The following is a description of a gene set: Human Gene Set: GSE17721_CTRL_VS_PAM3CSK4_0.5H_BMDC_UP Genes up-regulated in comparison of control dendritic cells (DC) at 0 h versus those stimulated with Pam3Csk4 (TLR1/2 agonist) at 0.5 h. from publication Amit I, Garber M, Chevrier N, Leite AP, Donner Y, Eisenhaure T, Guttman M, Grenier JK, Li W, Zuk O, Schubert LA, Birditt B, Shay T, Goren A, Zhang X, Smith Z, Deering R, McDonald RC, Cabili M, Bernstein BE, Rinn JL, Meissner A, Root DE, Hacohen N, Regev A (PMID 19729616) mouse primary BMDCs were stimulated with tlr ligands and gene expression changes were profiled on Affymetrix arrays studied in species Homo sapiens, and this is the list of marker genes: SOX21, CDK2 (cyclin dependent kinase 2), UBA3, ABAT, DOCK2, NCOA4 (NCBI Gene Id 8031), HNRNPM, RANBP17, STARD3NL, RNF32, INO80C, SEPTIN8, SNRPD3, DLD, SCLY, NDUFAF1, STK16, TCF21, RNF5, RPL3L, PIK3AP1, CCDC137, IL9R, SERTAD3, SNAP23, KAT2B, KARS1, ITGA4, SOCS5, HSDL2, SH3GL2, PDE2A, PSME4, POLG, FBXW11, TMEM175 (transmembrane protein 175), INO80, UHMK1, SLC46A2, BNIP2, XPO4, SAE1, PPP4R2, EQTN, USP9X, VPS50, NAA40, CMTM6, AGL, CASP7, P2RY12, HNF1B, CCDC6, SENP2, UBE2N, JAK1, PFKL, C6orf120, ZNF14, ENTR1, EIF3K, PBX3, ECHDC1, ERLIN1, MGAT2 (NCBI Gene Id 4247), GCNT2, TP53INP2, CHMP7 (NCBI Gene Id 91782), CENPA, NDUFA7, CAMK2A, WDR43, PRPF38B, USP38, TAF4, CABP7, KYNU, VPS35, GATAD2A, SLC23A3, FKBP7, UMPS, USP15 (ubiquitin specific peptidase 15), COCH, TBPL1, LEPROT, MYO5B, ENTPD1, GCSH, UGT2B17, ANKRD28, FAR1, CELA1, TTC14, PLEKHA2, ASH2L, COL5A2, MTFR1, EVA1C, TMEM216, SHC1, NME6, CD44, IFT70B, ABL1, EPS15, LCN8, RIMOC1, HJURP, WRAP53, POLR3F, FAM117B, CGGBP1, BAIAP2, MNX1, SACM1L, DGAT2, BSG, YEATS4, PSMB7, QTRT1, SMPD2, GPRASP1 (G protein-coupled receptor associated sorting protein 1), BLTP2, MRPL49, TXNRD3, KLHDC4, RPRD1A, PLAA, ATP6V1A, FBXO11, PRKCQ, RNF111, PKDREJ, SEC61G, RP2, SRSF1, ANAPC1, ADTRP, RGS8 (regulator of G protein signaling 8), PIAS2, CENPH, FZR1, FLOT2, TRIM34, NEAT1, CSTPP1, TK1, DAD1, LY75, DPYD, C7orf25, OSR2, MTERF3, VRK2, CYBB, NSUN2, NDST1, CHD1, TMEFF2, TIA1, MDH1, CDK20, ADD1, IREB2, TMEM179B, CNOT6L, CCNE1, TRIM8, TMED7, ANKH, ADAT1, IL2RG, NMRK1, KLRK1, MUC1, CLTC, MTMR1, CCNI, NEU2, GNAI3, FGL2 (NCBI Gene Id 10875), PIK3C2A, SYAP1 (NCBI Gene Id 94056), SHOX2, TMEM268, ME1, N4BP3, RPS2, SLFN12, CD52, ZC3H8, TADA2A, UBAP1, CAD, NUCB2, CDADC1, DYNLT4, AHCTF1, NHERF4